The following is a description of a gene set: The division of the cytoplasm and the plasma membrane of a cell and its partitioning into two daughter cells. studied in species Mus musculus Mouse Gene Set: GOBP_CYTOKINESIS, and this is the list of marker genes: Chmp2a, Bbs4, Cul7 (NCBI Gene Id 66515), Washc1, Iqgap1, Daxx, Stx2, Snx9, Shcbp1l, Rock1, Tas2r124, Spast, Klhl9, Rhoc, Kif20b, Ist1, Setd2, Rxfp3, Exoc6b, Stmn1, Ckap2, Myh10, Pdxp, Chmp5, Plk1, Plk3, Cdc14b, Septin11, Cdc42, Zfp365, Brca2, Myo19, Mrgprb1, Sptbn1, Chmp2b, Trim36, Kif3b, Anxa11, Pik3r4, Dctn3, Exoc7, Septin12, Aurka, Cspp1, Chmp1b, Septin9, Septin14, Exoc4, Chmp4c, Cep55, Nusap1, Myh9, Pkn2, Bcl2l1, Cetn2, Vps4a, Spire2, Iqgap2, Cdc25b, Calm3, Svil, Cfl1, Actr3, Tex14, Kif4, Septin6, Cntrob, Lzts2, Spire1, Git1, Rab11fip3, Zfyve19, E2f8, Dstn, Plec, Wnk1, Cdc14a, Klhdc8b, Luzp1, Exoc2, Septin4, Rhoa, Chmp6, Sh3glb1, Aurkb, Ccdc66, Myh14, Ank3, Iqgap3, Ahctf1, Kif13a, Mitd1, Rab35, Prkce, Exoc5, Septin7, Pstpip1, Aurkc, Cxcr5, Kif23, Becn1, Cdca8, Entr1, Tas2r121, Spart, Map10, Poldip2, Map9, Fsd1, Fmn2, Filip1l, Kif14, Washc5, Mei1, Gipc1, Diaph3 (NCBI Gene Id 80466), Exoc6, Anln, Drd3, Rhob, Rtkn, Sstr5, E2f7, Unc119, Septin3, Jtb, Tas1r2, Atxn10, Tas2r102, Septin1, Arf6, Exoc3 (exocyst complex component 3), Drd2, Prpf40a, Klhl13, Cenpa, Zfyve26, Ect2, Prc1, Septin2, Pdcd6ip, Pin1, Rab11fip4, Chmp4b, Birc5, Cul3, Racgap1, Arl3 (NCBI Gene Id 56350), Igf1r, Calm1, Stambp, Alkbh4, Exoc1 (NCBI Gene Id 69940), Cenpv, Birc6, Septin10, Incenp, Pik3c3, Calm2, Ccp110, Exoc8 (exocyst complex component 8), Cdc6, Son, Chmp7, Klhl21, Usp8, Mtmr4, Snx18, Orc4, Kif20a, Actr2, Apc, Chmp3, Chmp1b2, Uvrag, Chmp1a, Vps4b, Nup62, Rab11a, Snx33, Arf1, Ankrd53, Pkp4, Efhc1, Rock2, Cit, Septin8, Septin5